Given this list of marker genes FN3KRP, PRKX, TM6SF2 (NCBI Gene Id 53345), GPR176, CAPN10, RTCB, SNTG1, STXBP6, AGT, GPBP1L1, CTCF, GFOD2, CALCOCO1, TIAM2, WDR45B, NASP, MX2, EPHA1, GCNT4, RNF139, RBM14, MAL, PCDHGA1, AQP1, PROSER1, SYNE1, TBX10, RPL37A, CD247, GBF1 (NCBI Gene Id 8729), ZDHHC4, CELSR2, TMF1, IL10RA, MAU2, HCFC1, NMBR, ACAD10, CBFA2T3, PIGH, PI15, ITPKB, HLA-B, GPR21 (NCBI Gene Id 2844), LPCAT1, ADGRA3, KCNK15-AS1, IL18RAP, RASSF7, ANK3, CRACDL, VTN, ATP8A2, KIR2DL3, USP39 (NCBI Gene Id 10713), IFNA7, P3H1, CST8, ST8SIA4, GAB1, LRRC41, HP1BP3, LRIG2, TAF1, SLC25A15, XKR8, RBM23, VPS37B, RUSF1, BUB3 (NCBI Gene Id 9184), TLE2, STK32B, HBZ, CSNK1G2, YPEL1, GPR171, EIF4H, BIN2, GNG4, LRRC37BP1, ERCC3, VCL, HSF2, SEPTIN6, STAT4, E4F1, ODF2, ZBP1, HARS1, KRTAP5-9, POLA1, MARCHF8, ZNF34, MYO16, ZNF266, TLE4, PPP1R13L, DEF6, KIAA0586 (KIAA0586), MED16, DBT, PPP3CC, RWDD2B, TSPAN1, CYTH4, CACNA1G, FSTL1, IGSF9B, SYT1, MEGF9, CST1, ZNF473, OR11A1 (olfactory receptor family 11 subfamily A member 1), NPRL2, BBS9, LOXL3, RNF8, CYP2C9, NFIL3, AKAP6, HEG1, TRAF3IP3, ELF4, RUSC1, MLLT10, APBB3, CHRNA5, RDH16, GSTA1, ADGRE5, PMP2, ADAMTSL4, TCTA, RLN1, PIK3C2G, NPAS3, UNC5B, NRTN, POLR3D, FCGR3B, ZNF286A, EXO5, ICAM3, CDK13, PCSK2, THSD7A, NKX3-1, C15orf39, PITPNC1, MTHFSD, SLC10A3, PIGO, APBA3, POLR1F, CHST12 (NCBI Gene Id 652072), MAPRE2, MCC, RPUSD2, PKD1P1, NLE1, SMPD3, CYP1A2 (cytochrome P450 family 1 subfamily A member 2), TMEM204, DNAH2, RAB26, LINC01278, LMCD1, CFB, PKD1P6, ALOXE3, HAVCR1, MUC3A, SYNE2, VEGFC, NAP1L2, THAP4, DGKI, CTDSP1, PTPRD, NKX6-1, JADE2, KCNA1 (potassium voltage-gated channel subfamily A member 1), SLC37A1, SYNGR3, NFIB, RBCK1, APOA1, MRPL49 (NCBI Gene Id 740), ZNF862, DAZAP2, NRL, ATP2B4, PCNT, ANKZF1, PKNOX2, GZMM, CEP72, SLC35E2B, here is a description of the gene set: from publication Jeffrey KL, Brummer T, Rolph MS, Liu SM, Callejas NA, Grumont RJ, Gillieron C, Mackay F, Grey S, Camps M, Rommel C, Gerondakis SD, Mackay CR (PMID 16474395) species: Homo sapiens Genes down-regulated in comparison of macrophages versus NK cells. Human Gene Set: GSE3982_MAC_VS_NKCELL_DN In the present study we used Affymetrix oligonucleotide microarrays to produce gene transcription profiles for the major leukocyte types in humans. This comprehensive dataset enabled us to not only establish which genes were expressed in each leukocyte type, but also which genes were expressed in each subset after activation. The used of a comprehensive dataset of gene profiles from all the major human leukocyte subsets enabled a novel and powerful means for identification of genes associated with single leukocyte subsets, or different immune paradigms.